Given this list of marker genes Csrp3, Bin1, Ank2, Fer1l5, Myof, Dysf, Sypl2, Atp2a2, here is a description of the gene set: studied in species Mus musculus Mouse Gene Set: GOBP_T_TUBULE_ORGANIZATION A process that is carried out at the cellular level that results in the assembly, arrangement of constituent parts, or disassembly of the T-tubule. A T-tubule is an invagination of the plasma membrane of a muscle cell that extends inward from the cell surface around each myofibril.